Given this list of marker genes Msh2, Ercc1, Zscan4c, Dmc1, Gen1, Msh3, Xrcc4, Blm, Terf2, Xrcc3, Rad51d, Mlh1, Nsmce2, Ercc4, Tert, Smc5, Ercc2, Rad51c, Xrcc1, Ankle1, Rad52, Brca2, Rad50, Rad51, Smc6, Tep1 (telomerase associated protein 1), here is a description of the gene set: The exchange, reciprocal or nonreciprocal, of genetic material between one DNA molecule and a homologous DNA region that occurs during mitotic cell cycles. Mouse Gene Set: GOBP_MITOTIC_RECOMBINATION studied in species Mus musculus